Given this list of marker genes KNSTRN, PALB2, FBLN5, ERCC6, WARS1, THOC6, PPP2R3C (protein phosphatase 2 regulatory subunit B''gamma), PIK3CD, XRCC4, HS2ST1, MCPH1, PBX1 (NCBI Gene Id 5087), GNB2, ADGRG2, ASPM, CIT, CDC42, TMCO1, GATA3, KCTD1, CDK5RAP2, TRAPPC10 (trafficking protein particle complex subunit 10), WDR62, SCAF4, SARS1, NADSYN1, FREM2 (NCBI Gene Id 341640), STS (steroid sulfatase), KNL1 (kinetochore scaffold 1), WNT4, ALKBH8, TRAPPC14, WBP11, LMBRD1, MBTPS2, STX5, TBX1, SON, H4C9, ROBO1, PHC1, TRPV6, KYNU, CFTR, PPP2R1A, IDH1, PUF60, COPB2, GLI3, POR, ASXL2, PROKR2, TAF13, RTTN, SF3B4, NUP37, PTPN11, ANOS1, MFSD2A, CDK6, CEP63 (NCBI Gene Id 80254), NCAPD3, ELN, GDF6, CEP152, RPL26, PRKAR1A, TNXB, CEP135, RAP1B, ERCC8, SASS6, ALDH18A1, NSDHL, CRELD1 (NCBI Gene Id 78987), COG6, ATN1, PPFIBP1, PYCR2, ANKRD17, TBXT, CENPE, DSTYK, STIL, KDM6A, CTU2, ANKLE2, EYA1, METTL5, DYRK1A, FREM1, HNF1B, TXNL4A, TMEM67, MCM7, FANCL, KIF14, DHCR7, SIX1, KMT2D, here is a description of the gene set: studied in species Homo sapiens Human Gene Set: HP_UNILATERAL_RENAL_AGENESIS A unilateral form of agenesis of the kidney. Unilateral renal agenesis